Given this list of marker genes F5, SEC24B, TMED10, TRAPPC6A, CTSC, BET1, NSF, SEC24A, CD59, LMAN1, TRAPPC2, SCFD1, SAR1B, RAB1B, SEC22A, TBC1D20, LMAN2, TRAPPC6B, GOSR2, FOLR1, STX5, STX17, SEC23A (NCBI Gene Id 353367), TFG, TRAPPC2L, TRAPPC4, YKT6, NAPA, MCFD2 (NCBI Gene Id 90411), NAPG, TMED2, COL7A1, NAPB, SEC22C, TRAPPC1, AREG, CNIH3, TRAPPC3, GOLGA2, CTSZ, SEC22B, LMAN2L, SERPINA1, CNIH2, PPP6R1, TRAPPC10 (NCBI Gene Id 7109), SEC13, RAB1A, SEC23IP, TGFA, TRAPPC5, F8 (coagulation factor VIII), SEC24C, PPP6R3, USO1, SEC31A, SEC24D, ANKRD28, SEC16B (NCBI Gene Id 89866), LMAN1L, CSNK1D, PREB, GRIA1, SEC16A, TRAPPC9, PPP6C, SEC31B, CNIH1, GORASP1, here is a description of the gene set: studied in species Homo sapiens Reactome Pathway: COPII-mediated vesicle transport COPII components (known as Sec13p, Sec23p, Sec24p, Sec31p, and Sar1p in yeast) traffic cargo from the endoplasmic reticulum to the ER-Golgi intermediate compartment (ERGIC). COPII-coated vesicles were originally discovered in the yeast Saccharomyces cerevisiae using genetic approaches coupled with a cell-free assay. The mammalian counterpart of this pathway is represented here. Newly synthesized proteins destined for secretion are sorted into COPII-coated vesicles at specialized regions of the ER. These vesicles leave the ER, become uncoated and subsequently fuse with the ERGIC membrane. part of: ER to Golgi Anterograde Transport